The following is a description of a gene set: Genes up-regulated in blebbishields compared to control RT4 live cells species: Homo sapiens Human Gene Set: JINESH_BLEBBISHIELD_VS_LIVE_CONTROL_UP from publication Jinesh GG, Kamat AM (PMID 28855211) Apoptosis is a process that kills cells. However, cancer stem cells find ways to escape death after commencement of apoptosis. One such mechanism is blebbishield emergency program, in which the apoptotic cancer stem cells first undergo apoptotic body formation but then reassemble apoptotic bodies with main body (nuclei containing) of the apoptotic cells to form spherical to elongated structures called blebbishields. Blebbishields in turn are capable of blebbishield-blebbishield fusion to form transformed stem cell spheres (transformation phase) and then give rise to individual cancer cells from spheres (exit phase). We identified blebbishield emergency program in RT4 bladder cancer cells (RT4P=parental) and did microarray analysis of live RT4P cells, blebbishields and transformed spheres. This data set is a comparison of RT4P live cells with blebbishields and the gene list includes the genes that are upregulated in blebbishields. A separate set is provided for downregulated gene list too. In addition we provide separate gene lists for upregulated and downregulated gene lists for transformed spheres compared to blebbishields., and this is the list of marker genes: NUPR1 (NCBI Gene Id 26471), ATP2B1-AS1, SLC4A5, H3C7, EIF2AK4, MAPK8IP3, SULT1A2, ARL16, ATP5IF1, H4C5, TBCD, STC2, CEP19, CHTF18, JHY, FKTN, COL7A1, ZNF486, TDRD1, FOS, ME3, CTSV, ZNF394, CEBPG, DENND2D, GDPD1, RAD51C, AADAC, BLOC1S6 (NCBI Gene Id 26258), PLD1, ENSG00000261335, FRMD6-AS2, HERC2 (HECT and RLD domain containing E3 ubiquitin protein ligase 2), YJU2B, DDIT4, AFDN, RASIP1, GABPB2, DENR, PCDHB9, NPIPB11, USP49, ALDH1A1, UPF2 (UPF2 regulator of nonsense mediated mRNA decay), ZNF652, MCMDC2, SLC35E1 (NCBI Gene Id 79939), PLIN5, VWF, CRCP, SNORD13, TNK2, SPTLC1, VARS2, TNFSF15, TRPM6, KCNMB4, EID2B, BEGAIN, ZNF750, IL18, H3C14, TSC22D3, SNORD25, NLRP8, WFIKKN1, PPM1K, GADD45A, DDIT3, RPS13, TRIB3, HSD17B7, HROB, NDUFAF7, INPP5D, ITPK1-AS1, H2BP1, SARS1, SCIN, RHBDL2, MYO3B, TIMP3 (TIMP metallopeptidase inhibitor 3), CHRNA5, VPS41, IKBIP, FMC1, H2AC6, HSCB, RRM2B, BRICD5, FGD3, CDKN2AIPNL, ZNF14, MBTD1, IL17RD, LEP, CDKN1A, HOXB6, MCF2L-AS1, DEPP1, GSK3B, COA8, DDX56, IGFL2-AS1, DEPTOR, TRIAP1, ZMAT3, SAC3D1, COL24A1, DOP1B, ZNF577, H2BC8, SNAPC1, TDG, RECQL4, LILRB1, SLC26A11, OCIAD1, DDX51, MBD4, ZNF526, S100A14, COASY, H4C12, SPDYE1, KIAA0408, NUTM2E, SOX9, DMC1, CPT1B, FUT6, ERCC6L2-AS1, CSRNP1, AKR1D1, INKA2, H2BC5, NRDE2, WDR20, KRT20, SERTAD1, GAS6, PPA2, ZNF223, GRB14, FKBP14, N4BP2, TIGAR, RGS12, MRM2, RNU11, LMOD3, TENT5A, PCED1B, RPPH1, MAMDC4, RPL10L, CARS1, PTP4A2, ABCA7, MCM8 (NCBI Gene Id 84515), AKR1C2, H2AC17, ZNF296, ACOT2, CYFIP2, RNU12-2P, SULT2A1, SPDYE6, AEN, EXO5, KIFC2, CEP85L, SBF1, FOXC1, SNORD55, ERAP2, MRPL27, PRRG4, H3C1, KREMEN2, H4C2, GLUL, EGR1, CDK10, CEL (carboxyl ester lipase), KLF4, RHOT2, XYLT1, NADSYN1, SCRIB, AVPI1, H3C10, CBS, LRRFIP1, PSAT1, BCYRN1, TNFSF14, NUP50, BIRC3, IL10, S100A4, NUDT1, KNTC1, GCLM, SERF2, MC1R, GALNT3, DAPP1, LIN52, RBM15, GDF15, TDP1, CCN1, MINDY1, XPNPEP3, TBC1D32, SALL4, AIRE, GRIPAP1, HSPA8, AAK1, IGF2R, RPS3, SSTR2, NOTCH1, INPPL1, LONP1, TRIM13, HAUS2, FCGR3A, XRCC2, NPIPB15, RNF213, ZNF587 (NCBI Gene Id 84914), DCLRE1C, RGS16, CCDC144A, RBM3, SULT1A1, ATF4, SLC44A4, RNU6ATAC, SLC5A8, ANKRD11, TSKU, MAF, ZNF669, RPL4, RBM14, ZNF682, MARS1, MORC2, INTS1, ANKRD20A1, GPT2, ZNF69, TCAF1, SLC3A2, PLA2G2D, TUBGCP6, GRIN2C (NCBI Gene Id 2905), KCNH6 (potassium voltage-gated channel subfamily H member 6), PPM1D, ANKRD20A11P, HNRNPU, HYKK, SHROOM4, SPP1, ZNF880, LINC01684 (NCBI Gene Id 400860), FOSB, PILRB, ZNF483, ANKRD11P2, SPDYE10 (NCBI Gene Id 643862), YTHDC1, POFUT1, FCAR, ZNF93, CMKLR2, BRI3BP, LXN, TAF13, PDE4C, CCBE1 (NCBI Gene Id 147372), METTL21A, RPL13A, MUC20, TRMT1, UGP2, DTWD2, RTTN, ANKRD30B (ankyrin repeat domain 30B), GLS2, MIB2, SHCBP1, NPIPB3, ID2, LINC01720 (NCBI Gene Id 440704), INIP, H3C4, PIP4K2B, MYRFL, KRT13, POMT1, HMOX1, TBC1D3K, SLC7A5, CCDC137, DUSP1, PGF, DHRS9, CREB1, CDK11B, ARL4A, SDHAP1, TMEM17 (NCBI Gene Id 200728), MDM2, FRY, HNMT, TYMSOS, EPDR1, CUL9, NPIPB12, FER1L4, NOP56, H2BC3, AOC4P, PNPT1, IFRD1, CFAP74, CYP2S1, PTGR2, LINC00243, RAX2, ZNF549, KITLG, LIME1, TSSC4, ICA1, PHAX, JMJD7-PLA2G4B, H2AC8, GSDMB, CBX4, DDB2, ZMYND15, NXF1 (nuclear RNA export factor 1), TMEM184A, LILRB3 (NCBI Gene Id 11025), CD68 (NCBI Gene Id 968), TYMS, ALPP, NPIPB13, MAFF, GJC1, EPAS1, ZNF430, PIDD1, CDAN1, CSF2RA, ALB, WDR74, TMEM107, RN7SK, BLZF1, SESN2, ASNS, H1-0 (NCBI Gene Id 3005), SULT1A3, ANKRD44 (NCBI Gene Id 91526), NUBPL, DCAF11, CATSPER2, YRDC, SEMA3E, IER5L, ZNF786, PATE2 (NCBI Gene Id 399967)